The following is a description of a gene set: Mouse Gene Set: GOBP_REGULATION_OF_NEURON_PROJECTION_DEVELOPMENT Any process that modulates the rate, frequency or extent of neuron projection development. Neuron projection development is the process whose specific outcome is the progression of a neuron projection over time, from its formation to the mature structure. A neuron projection is any process extending from a neural cell, such as axons or dendrites (collectively called neurites). species: Mus musculus, and this is the list of marker genes: Sema5a, Tsku, Tbx6, Rtn4ip1, Cd24a, Robo1, Tmem106b, Rapgef1, Nrg1, Braf, Neurog3, Mag, Ache, Ppp3ca, Plxnb3, Shtn1, Grid2, Cspg4, Sphk1, Cib1, Cask, Neu1, Fgfr1, Chrna3, Gdi1, Mir124a-3, Fig4, Actr3, Stx1b, Slitrk1, Akt1, Pdlim5, Wnt7a, Chn1, Eif4g2, Adam10, Neo1, Map6, Trim46, Crabp2, Negr1, Caprin2, S100a9, Nfatc4, Pax6, Sgk1, Avil, Dtnbp1, Arf6, Golga4, Tbr1, Efna1, Adgrb3, Nme1, Kndc1, Plxnc1, Hecw2, Ilk, Cers2, Ptk7, Nfe2l2, Lpar1, Ifrd1, Id1, Nckipsd, Ptprs (NCBI Gene Id 19280), Gorasp1, Brsk2, Hdac6, Epo, Rufy3, Cacna1a, Sema4d, Snap25, Bdnf, Mylip, Tbc1d24 (NCBI Gene Id 224617), Minar1, Ptprf, Wnt5a, Pak3, Grin1, Kdm1a, Ccdc88a, Nsmf, Shox2, Mtor, Lrrc4c, Abi3, Dcc, Mob2, Fyn, Enc1, Alkal2, Rtca, Crk, P3h1, Nedd4, Cbfa2t2, Cux2, Cxcl12, Dnm1l, Trim67, Adcyap1, Ulk1, Rapgef4, Lpar3, Zfyve27, Ulk2, Ptn, Abl2, Inpp5j, Nr2e1, P2ry2, Ncs1, Arhgap33, Fbxw8, Diaph1, Lrp6, Bag5, Wls, Csmd3, Dnm3, Wnt3a, Ep300, Fgf13, Atp1b2, Ptpn9, Cntn1, L1cam, Il15ra, Rit2, Cdh4, Trak2, Xylt1, Ap2a1, Nck1, Ppfia2, Dbn1, Dvl1, Snapin, Crtc1, Mdm2, Kif1a, Ppp2r5d, Kif26a, Mbp, Rgma, Ndel1, Kidins220, Eef2k, Atoh7, Twf1, Akap5, Smn1, Klf4, Crp, Thoc2, Mfn1, H2-K1, Prkci, Agt, Plk5 (NCBI Gene Id 216166), Map4k4, Map1b, Mark2, Ngef, Ust, Runx1t1, Kalrn, Atp8a2, Rhoa, Lrp8, Cyfip1, Lgals1, Gata3, Mboat1, Lrig2, Mfsd2a, Kat2b, Cux1, Myo5b, Parp6, Tsc1, Stau2, Atf1, Eif2b2, Ptprz1, Thy1, Obsl1, Pou3f2, Pafah1b1, Arhgap35 (Rho GTPase activating protein 35), Sfrp1, Ppp2r5b, Afdn, Fzd1, Hap1, Dync1i2, Pak1, Scarb2, Ptk6 (PTK6 protein tyrosine kinase 6), Katna1, Carm1, Ist1, Nme2, Amigo3 (NCBI Gene Id 320844), Cdk5r1, Tsc2, Dlg4, Trpc5, Khdc3, Shank3, Fzd4, Cul7, Setx, Gpc2, Nedd4l, Frmd7, Grip1, Itga6 (integrin alpha 6), Adam17, Plxnd1, Prkd1, Caprin1, Gak, Cflar, Elavl4, Limk1, Styxl1, Tnr (NCBI Gene Id 21960), Xk, Ngfr, Rtn4rl2, Hspa5, Cx3cl1, Magi2, Crmp1, Cdkl3, Dleu2, Map2k1, Stk25, Vldlr, Sema6c, Ptbp1 (polypyrimidine tract binding protein 1), Retreg3, Nrcam (NCBI Gene Id 77467), Pak2, D130043K22Rik, Rap2a, Qki, Kel, Xlr3b, Htr7, Picalm, Sh3glb1, Ntn1, Spart, Sema3g, Tnn, Camk2g, Ube3a, Ptprd, Nrxn1, Rtn4, Mfn2, Skor2, Cyth2, Rab17, Igf1r, Ptk2b, Opa1, Ntrk2, Kif21a (kinesin family member 21A), Gfap, Sema3f, Fstl4, Cobl, Rgs2, Ephb3 (NCBI Gene Id 13845), Ndrg4, Cdk5, Numb, Sema7a, Dynlt1f, Ptpn1, Ryk, Nox1, Bmp4, Rap1gap2, Dpysl2, Gsk3a, Fes, Zdhhc15, Shoc2, Bmpr2, Reln, Actr2, Abl1, Lrrk2, Sirt1 (NCBI Gene Id 93759), Sema4f, Tox, Itpka, Cdkl5, Il6, Metrn, Rtn4rl1, Sfrp2, Fbxo38, Brsk1, Tenm3, Pla2g3, Chrnb2, Cntn2, Adamts1, Sarm1, Vim (NCBI Gene Id 22352), Flna, Met, Cd38, Dkk1, Bhlhb9, Cfl1, Kank1 (KN motif and ankyrin repeat domains 1), Arhgap32, Efnb3, Trpv2, Cdh1, Amigo1, Bcl11a, Acap3, Il1rapl1, Baiap2, Crkl, Inppl1, Dennd5a, Fezf2, Dynlt1a (NCBI Gene Id 100310872), Hnrnpk, Ntrk3, Acp4, Hspb1 (NCBI Gene Id 15507), Ntng2, Itga3, Iqgap1, Nlgn1, Hgf, Tmem30a, Ube2v2, Ddx56, Adcy10, Disc1, Nova2, Syngap1, Map3k13, Fbxo7, Ehd1 (EH-domain containing 1), Stmn2, Katnb1, Gprc5b (G protein-coupled receptor, family C, group 5, member B), Draxin, Megf8, Dab2, Abi2, Efemp1, Adcy6, Washc5, Apoe, Pcp4, Fkbp1b, Tiam1, Ptk2, Pten, Zfp804a, Cit, Slit1, Nrdc, Tnfrsf12a, Dab1, Ss18l1, Islr2, Trpv4, Mark1, Scn1b, Rnd2, Psen1, B2m, Ngf, Gfi1, Map2k2, Slit2, Hes1, Paqr3, Mir124a-2, Cxcl5, Ptpn5, Epha3, Cpeb1, Fn1, Robo2, Hecw1, Numbl, Alk, Fbxo31, Kif3c, Prag1, Ret, Mir124a-1, Dscam, Ezh2, Sema6d, Plppr5, Kif13b, Nefl, Scarf1, Ttc3, Prrx1, Rtn4r, Dixdc1, Anapc2, Cnr1, Rapgef2, Epha7, Ankrd1, Macf1, Dmd, Fat3, Sema3a, Lrrc7, Nptn, Fut9, Camsap2, Serpini1, Vegfa, Stk11, Ephb2, Marcks, Snx3, Prex1, Tiam2, Dbnl, Zeb2, Rrn3, Pqbp1, Rpl4, Ahi1, Gsk3b, Acsl6, Rnf6, Fxn, Ntng1, Golga2, Lzts1, Ntrk1, Lif, Snap91, Grn, Mdk, H2-D1, Skil, Efna5, Tubb2b, Camk2b, Gla (galactosidase, alpha), Alkal1, Creb3l2, Pum2, Trpc6, Zfp296, Dcx, Adnp, Dab2ip, Abi3bp (ABI family member 3 binding protein), Bmp7, Camk1d, Ranbp1, Ulk4, Ltk, Spock1, Tanc2, Ankrd27, Ppp1r9a, Sipa1l1 (signal-induced proliferation-associated 1 like 1), Ntm, Itpr1 (NCBI Gene Id 18544), Nr2f1 (nuclear receptor subfamily 2, group F, member 1), Mir212, Mapt, Chodl, Mgarp, Diaph2, Lrp1, Klk6, Prkcsh, Rab21, Slc39a12, Agrn, Ccr5, Nrp1, Ctnna2, Dip2b, Arhgap44, Cdh2, Nlgn3, Cntf, Pacsin1, Bmp5, Map2, Arc, Srcin1, Ywhah, Pias2, Ikbkb, Stk24, Pmp22, Plxna3, Ddr2, Rab29, Dhx36, Ndnf, Dguok, Plxnb2, Efnb2, Arsb, Itgb1, Nin, Apbb1, Zfp365, Epor, Tnik, Efhc2 (EF-hand domain (C-terminal) containing 2), Cdc20, Sdc2, Lrp4, Twf2, Mt3 (NCBI Gene Id 17751), Epha4, Dpysl3, Inpp5f, Wnt3 (wingless-type MMTV integration site family, member 3), Dpysl5, Neu4, Smurf1, Fez1, Pou4f2, Nf1, Mir132, Lyn, Serpine2, Itm2c, Camk1, Mycbp2, Dynlt1b, Kremen1, Arhgap4, Plxnb1, Slc30a1, Robo3, Trak1, Fkbp4, Rap1a, Sez6, Ptprg, Nefm, Srf, Hdac2, Dynlt1c, Lzts3, Clip1, Omg, Sf3a2, Dgkg, Tlx2, Serpinf1, Ddr1, Ythdf1 (YTH N6-methyladenosine RNA binding protein 1)